Given this list of marker genes CISH, CDC6, GMNN, PLIN2, BHLHE40, NRP1, RAD51, TBL2, FASLG, KIF4A, LIG1, CCNF, RAB11A, S100A6, RNASEH2B, SERPINB6, EFHD2, H1-2, GLRX, ATP5IF1, SERINC3, MAPK6, KIF2C, TNFRSF9, CARHSP1, KIF20A, GZMK, CD48, CA1, GALNT3, VCL, LAG3, POLA1, SERPINB9, PRDX4, PRIM2, STMN1, FGL2 (NCBI Gene Id 10875), TYMS, PRDM1 (NCBI Gene Id 639), RHD, GZMM, LPIN1, TCF19, DLGAP5, CCR2, ADAM8, RHOQ, S100A10, C6orf89, ITGAX, EMP3 (epithelial membrane protein 3 (MAM blood group)), REEP5, MT2A, PLK4, IFI30, NCAPH, IGLC7, LGALS1, CDC45, KRTCAP2, NUDT4, MT1E, CD99, FHL2, PDCD1, CA2, CHAF1A, INCENP, KLRK1, STARD10, IFNG, AURKB, CDCA5, PLD4, SYPL1, TMEM14C, MCM5, RRM1, DTL, CKS1B, VPS51, CRMP1, RFC5, S100A4, MKI67, ITGB1, MCM10 (minichromosome maintenance 10 replication initiation factor), HOPX, MTM1 (myotubularin 1), CDKN3, ANXA1, GNPDA1, PRC1, NPPA, TOP2A, ROM1, SKAP2, MAPRE2 (microtubule associated protein RP/EB family member 2), GZMB, IFITM3, SOCS2, ANXA2, HPF1, ERRFI1, MIS18BP1, EEA1, TTK, CISD1, MS4A1, TKTL1, ACOT7, CAPG, DSTN, CASP3, CDC25C, BMP2K, CDK1, UBL3, ARHGAP21, LGALS3, BATF3, CYFIP1, CCR5, CDCA8, KIF22, KIFC1, IRF4, ODC1, ECT2, GZMA, CCNB2, DHFR, CD244, TXN, C3, MTMR9, GEM, CMC2, JCHAIN, PRIM1, IGKC, NAPSA, GCAT, KLRG1, IRF8, CDK2AP1, H1-0, UNC119, TPI1, LITAF, H2AZ1, BCL2A1, MAD2L1, ANXA4, EMP1, AURKA, MYADM, SH3BGRL, CAPN2, PRF1, PLSCR1, F2RL3, E2F8, GNG10, MDFIC, DOCK5, ELL2, CKS2, CHEK1, CCL4, UBE2T, PCLAF, CCNA2 (cyclin A2), BUB1, ASF1B, EZH2, BIRC5, PERP, NUSAP1, KIF11, PLP2, TMEM37, ASPM, SCPEP1, PCNA, BRCA1, PGAM1, LYN, MYO1F, SNX10, ANLN (NCBI Gene Id 54443), TACC3, CENPA (centromere protein A), NEK2, TK1 (thymidine kinase 1), CDKN2C, CDCA3, H2AX, FCER1G, here is a description of the gene set: studied in species Homo sapiens Human Gene Set: GOLDRATH_NAIVE_VS_EFF_CD8_TCELL_DN from publication Luckey CJ, Bhattacharya D, Goldrath AW, Weissman IL, Benoist C, Mathis D (PMID 16492737) The only cells of the hematopoietic system that undergo self-renewal for the lifetime of the organism are long-term hematopoietic stem cells and memory T and B cells. To determine whether there is a shared transcriptional program among these self-renewing populations, we first compared the gene-expression profiles of naïve, effector and memory CD8(+) T cells with those of long-term hematopoietic stem cells, short-term hematopoietic stem cells, and lineage-committed progenitors. Transcripts augmented in memory CD8(+) T cells relative to naïve and effector T cells were selectively enriched in long-term hematopoietic stem cells and were progressively lost in their short-term and lineage-committed counterparts. Furthermore, transcripts selectively decreased in memory CD8(+) T cells were selectively down-regulated in long-term hematopoietic stem cells and progressively increased with differentiation. To confirm that this pattern was a general property of immunologic memory, we turned to independently generated gene expression profiles of memory, naïve, germinal center, and plasma B cells. Once again, memory-enriched and -depleted transcripts were also appropriately augmented and diminished in long-term hematopoietic stem cells, and their expression correlated with progressive loss of self-renewal function. Thus, there appears to be a common signature of both up- and down-regulated transcripts shared between memory T cells, memory B cells, and long-term hematopoietic stem cells. This signature was not consistently enriched in neural or embryonic stem cell populations and, therefore, appears to be restricted to the hematopoeitic system. These observations provide evidence that the shared phenotype of self-renewal in the hematopoietic system is linked at the molecular level. Genes down-regulated in comparison of naïve CD8 T cells versus effector CD8 T cells.